The following is a description of a gene set: Human Gene Set: GOBP_NEGATIVE_REGULATION_OF_INTERLEUKIN_2_PRODUCTION Any process that stops, prevents, or reduces the frequency, rate, or extent of interleukin-2 production. species: Homo sapiens, and this is the list of marker genes: GATA3, IL20RB, SFTPD, VSIG4, MIR181C, CD34, HAVCR2, CR1, TBX21, NAV3, XCL1, PRNP (NCBI Gene Id 96713), GPR174, NR1H4, LAPTM5, LILRB4, FOXP3, TNFAIP3 (NCBI Gene Id 7128), PRKACA, PTPRC, HOMER3, HDAC7, TRIM27, GBP1, EZR, KAT5, LAG3, ZFP36, HOMER2